The following is a description of a gene set: Mouse Gene Set: MIR_199A_5P_MIR_199B_5P Genes predicted to be targets of miRBase v22 microRNA mmu_miR_199a_5p, mmu_miR_199b_5p in miRDB v6.0 with MirTarget v4 prediction scores > 80 (high confidence targets). species: Mus musculus from publication Chen Y, Wang X (PMID 31504780), and this is the list of marker genes: Ntng1, Rassf3, Cbl, Gcnt2 (glucosaminyl (N-acetyl) transferase 2 (I blood group)), Sulf1, Arhgap12, Apmap, Stk4, Nfil3, Ets1, Srgap3, Nsg1, Gorasp1, Evx2 (NCBI Gene Id 14029), Rnf38, Abca1, Agpat3, Gng5, Klhl20, Wapl, Atg14, Slc25a37, Apbb1, Fzd4, Lca5, Ddr1, Atxn7, Fzd6, Git1, Sos2, Mindy3, Flrt3, Wdr76, Lpl, Ccnj, Lrrc19, Hmcn1, Rgma, Pan3, Ap1g1, Mab21l1, Insig2, Thumpd3 (NCBI Gene Id 14911), Mvb12b, Myef2, M6pr, Nudt10, Pik3cd, Pxn, Myrf, Hapln1, Bend3, Rab9b, Med12, Vps26a, Aftph, Zfp704, Rfx3, Serpine1, Slc24a3, Ccdc120, Zmpste24, Clcn3, Tef, Map3k11, Acvr2b, Ppargc1a, Sun1, Caprin1, Taok1, Kpna4 (karyopherin subunit alpha 4), Als2, Sirt1, Clip1, Atp1b3, Ralgapa1, Txlnb, Slc25a23, Crppa, Cecr2, Bcam, Mgat4b, Tmem127, Atxn3, Hspa5, Cav1, Ino80d, Pals1, Arhgap21, Gpd2, Clock, Ece1, Arhgef4, Ccnl1, Tubg1, Mical3, Marchf8, Dao, Arl8b, Lin7c, Naa40, Ccdc43, Zfp781b, Zfp579, Hs3st5 (heparan sulfate (glucosamine) 3-O-sulfotransferase 5), Garre1, Taf9b, Klhl29, Tgfb2, Clvs1, Eif5b, Crebrf, Hspa12a, Large1 (LARGE xylosyl- and glucuronyltransferase 1), Ninl, Prdm16, Nsf, Plxna2, Dnaaf5, Cacna1b, Npas2, Zfp617, Celsr1, Nectin1, Pnpla6, Vwce, Zfp811, Podxl, Mitd1, Slc17a6, Tspan6 (tetraspanin 6), Rad23b, Slf2